The following is a description of a gene set: Human Gene Set: MIR550B_3P from publication Chen Y, Wang X (PMID 31504780) Genes predicted to be targets of miRBase v22 microRNA hsa-miR-550b-3p in miRDB v6.0 with MirTarget v4 prediction scores > 80 (high confidence targets). species: Homo sapiens, and this is the list of marker genes: ZNF552, CASP10, ZNF285, FHIP1A, LSM6, PRDM6, CDS1, SNRNP27, GANC, CCDC47, HTR2B, CLDN10, PPIH, PAK3, GPRASP3, CDC73, PDZD8, DYNC1I2, SFPQ, SEC11A, SREK1, SDAD1, STAG1, CTPS2, NMNAT2, FLRT3, EPB41L5, KIF13A, ROCK1, ASNSD1, CDIPT, GTF2H2, AFF4, MOBP, USP27X, VPS26A, MXI1, NUDT9, KRR1, TMEM232, MAP3K20, SMAD5, MOB3B, PAAF1, SHISA6, RBAK, CLHC1, EXTL2, TRPV3, ZC3HAV1, CCNA2 (cyclin A2), FBXO28, APOBEC3B, BNC2, MCMBP, CLEC4E, DLK1